Given this list of marker genes Dchs1, Zfpm1, Gata4, Notch1, Zfpm2, here is a description of the gene set: Mouse Gene Set: GOBP_MITRAL_VALVE_FORMATION The developmental process pertaining to the initial formation of the mitral valve from unspecified parts. This process begins with the specific processes that contribute to the appearance of the discrete structure and ends when the structural rudiment is recognizable. species: Mus musculus